Given this list of marker genes FANCM, XRCC3, HELQ, DMC1, RAD54L, RAD52, MCMDC2, RAD51C (NCBI Gene Id 5889), RAD51, here is a description of the gene set: species: Homo sapiens SDSA is a major mechanism of double-strand break repair in mitosis which allows for the error-free repair of a double-strand break without the exchange of adjacent sequences. The broken DNA searches for and base pairs with a homologous region in an intact chromosome. DNA synthesis initiates from the 3' end of the invading DNA strand, using the intact chromosome as the template. Newly synthesized DNA is then displaced from the template and anneal with its complement on the other side of the double-strand break. Human Gene Set: GOBP_DOUBLE_STRAND_BREAK_REPAIR_VIA_SYNTHESIS_DEPENDENT_STRAND_ANNEALING